The following is a description of a gene set: Mouse Gene Set: GOBP_NEGATIVE_REGULATION_OF_ACUTE_INFLAMMATORY_RESPONSE_TO_ANTIGENIC_STIMULUS species: Mus musculus Any process that stops, prevents, or reduces the frequency, rate, or extent of an acute inflammatory response to an antigenic stimulus., and this is the list of marker genes: Npy, Spn, Selenos, Il20rb (interleukin 20 receptor beta), Adcyap1, Npy5r, Fcgr2b